The following is a description of a gene set: Genes up-regulated in comparison of microglia cells 1 h after stimulation with IFNG versus microglia cells 6 h after the stimulation. studied in species Homo sapiens Human Gene Set: GSE1432_1H_VS_6H_IFNG_MICROGLIA_UP Microglial cells are resident macrophages in the central nervous system (CNS) and play a pivotal role in the innate and adaptive immune responses against microbial infections. The immune functions of microglia are regulated by a milieu of cytokines including interferon (IFN)-gamma. We here performed a series of experiments to acertain the transcriptional profile of human fetal microglial cells at 1, 6, and 24 h after IFN-gamma treatment. Primary human microglial cells were either untreated or treated with 200u/ml IFN-gamma. Affymetrix U133A chips were utilized. Four different tissue samples (B18, O, W, and Y20) were analyzed at the three time points. from publication Rock RB, Hu S, Deshpande A, Munir S, May BJ, Baker CA, Peterson PK, Kapur V (PMID 16163375), and this is the list of marker genes: LPCAT1, SATB1, ARHGAP26, MEST, ADSS2, UBE4B, NUP98, PCDHGA1, FAM168A, RASGRP3, REV3L, GIPC2, ELOVL6, GADD45G, MDH2, FGL1, OSBPL10, PSD4, RWDD2A, TLE3, LLGL2 (NCBI Gene Id 3993), MTMR3, TAAR2, SSH1, ATP2B3, RXRA, SNCA, MCM6, DESI2, SLC4A7, FGFBP1, NHERF1, CERK, REG1B, SPATA2, CCR9, SOCS2, ZMAT3, HBS1L, GRAMD4, PFDN1, SOX18, FOXO1, SHB, PPM1H, MPP1, ECM2, NINJ2, KLHL11, STARD5 (StAR related lipid transfer domain containing 5), RNASET2, TBC1D13, RWDD2B, PREX2, LDLRAD4, NPY6R, ITPKB, CISH, FBXO5, SATB2, DNMBP, ALDH4A1, HMOX1, CEP131, RPP40, OAZ1, SLA, PICK1, XYLT1, BABAM1, FARP1, COX7A2, TRAK1, SLC25A36, RCOR1, GFOD1, ABHD5 (abhydrolase domain containing 5, lysophosphatidic acid acyltransferase), NDC1, CLCN3, STK17B, FGF7, CROCCP2, LRPPRC, CDC37L1, TMEM14B, HECA, WRAP53, PCDH8, SPSB3, CYTIP, TLCD3A, HLX, PPARD, TXLNGY, MYO7A, PLXND1, FAAP100, CHMP1B, HMGA2, ZMYM2, SNRPD2, VDR, AATK, ZNF451, CFAP70, TKT, AMPD2, JPT1, PHACTR1, ATP6V0E2, NET1, HSDL2, SLC17A9, MPI, HDHD5, CYP27A1, AURKA, MRS2, SS18L1, ABHD6, SESN1, COX4I1, MRPL57, SHTN1, FAM168B, RHOB, LRRC17, SRSF6, BDH1, DIP2C, MYL6B, MGST3, TRIB1, TMPO (NCBI Gene Id 7112), CCNB2, PDE3B, TPD52L1, AVPI1, SDR39U1, NBEA, CEP68, MNT, SLC38A6, MAP4K1, PEX16 (peroxisomal biogenesis factor 16), PARL, COQ2, SCGB1D1, ATIC, BEAN1, PPM1F, SOCS3, FAM162A, CRLF2, PFDN5, NCAPD3, CDC42EP4, PSG5, NMT2, TBC1D30 (NCBI Gene Id 23329), LGALS4, RABIF, CLCN1, MAOA, PRPF18, LGR4, NDRG3, USP46, FKBP9, FUT8, LY86, LSM7, WIPI1, SRSF9, DNAJB5, SCLY, PGM1, MAP2K6, KLHDC2, CTDSPL, CNTNAP1, BAIAP2, PDHB, PCCA, PKDREJ, KATNB1, TAX1BP3, TPST2, APBB3, RPL10A, PLCXD1, SNRNP25, KCNAB2, IFNA16, RGS2, SETD6, RTN3, STIL, PLXNA2, OGG1